Given this list of marker genes SPATA17, WNT2, ZNF710, CACNG3, GSK3B, PTCH2, MAML3, ARID1A, INTS12, IL11RA, GPATCH2, TLK1, FXR2, WASF1, RORA, TNFAIP8 (NCBI Gene Id 25816), TCF7L2, ZNF143, SYTL2, NRG1, ERLIN1, STAG2, LRCH4, CDC27, POLR1D, SH3GL3, RNF220, ANGPTL2, CASKIN2, GIPC1, TIMP3 (TIMP metallopeptidase inhibitor 3), CDC40 (NCBI Gene Id 51362), KDELR2 (KDEL endoplasmic reticulum protein retention receptor 2), ACTA1, DET1 (DET1 partner of COP1 E3 ubiquitin ligase), ARF6, THRA, SFXN2, ICA1, MYH10, ASXL1, POLD4, CALD1, DMD, BCOR, CBLN1, DNAJC22, LNX2, HMGN3, NCOA6, JMJD6, CDK5R2, RNF213 (ring finger protein 213), LIG1, RFX4, KCNIP1, GSTCD, ACTC1, SESN3, SEPTIN10, SKIDA1, GPATCH11, HOXC13, RTN2, DLX1, BTBD1, PARP8, BMPR2, ARGLU1, RAB33A, PCIF1, WDPCP, UBE2D3, ZSWIM9, SH2B3, SANBR, SENP1, PRP4K, XPR1, EPHA1, FGF5, FBXO24, RAB11A, ATP5MC2, MMP23B, HOXA10, MMP23A, OTUD7B, EIF4E, ZFX, NOL4L, ZNF800, ZBTB4, MEX3B, NECAP1, FAM222B, KNCN, TSEN54, GOLPH3L, PRPF38B, HIC2, CMTM5, RAPGEFL1, HPCA, PDZRN4, PGF, POLR2A, JADE2, ABCA2, RNF145, POFUT1, PPM1N, MNT, TNNC2, CCL20, NRF1, XIAP, ERBB2, LINC02908, EML1, CREB3L2, MAP3K5, RLIM, CALCR, SOWAHC, FLNC, PAIP2, DNAI4, SYNJ1, PRKCE, GAB2 (GRB2 associated binding protein 2), SRF, UBTF, CDK9, ARFIP2, IGDCC3, TRAF4, CTNNBIP1, NR2F1, CDH16, TIMM10B, SELENOH, TMEM132E, POU3F3, DNAL4, VCPIP1, EIF4G2, BAHD1 (bromo adjacent homology domain containing 1), ARL3, ARHGEF12, PACSIN3, SCNN1A, PLAGL2, RORC, MAF, NEUROD6, here is a description of the gene set: Human Gene Set: PAX5_01 Genes having at least one occurrence of the motif BCNNNRNGCANBGNTGNRTAGCSGCHNB in the regions spanning 4 kb centered on their transcription starting sites. This matches the PAX5 transcription factor binding site V$PAX5_01 (v7.4 TRANSFAC). studied in species Homo sapiens